The following is a description of a gene set: studied in species Homo sapiens Human Gene Set: BLANCO_MELO_COVID19_SARS_COV_2_LOW_MOI_INFECTION_A594_ACE2_EXPRESSING_CELLS_UP from publication Blanco-Melo D, Nilsson-Payant BE, Liu WC, Uhl S, Hoagland D, Møller R, Jordan TX, Oishi K, Panis M, Sachs D, Wang TT, Schwartz RE, Lim JK, Albrecht RA, tenOever BR (PMID 32416070) Genes up-regulated in SARS-CoV-2 low MOI infection (ACE2 expressing A549 cells, MOI: 0.2, 24hpi) Analysis of the transcriptional response to SARS-CoV-2 compared with other respiratory viruses, including MERS-CoV, SARS-CoV-1 (SARS), human parainfluenza virus 3 (HPIV3), respiratory syncytial virus (RSV), and IAV., and this is the list of marker genes: DCAF4L1, PTGS2, SNORA3B, SLCO5A1, FGG, ARHGAP40, SIX4 (NCBI Gene Id 51804), PER3, ZNF555, TCERG1L, MIR3685, NR4A1, SCARNA7, EREG, CCL4, LINS1, HRH3, CD300LB, INO80D, SNORD15B, ZNF654, DBP, IGFBP1, LSMEM1, ARHGAP30, CLK1, WRAP53, FST (follistatin), CCNL1, RIMOC1, FGA, GRHL1, FOXN2, TNF, NEURL3, H2AC15, IL1A, ZNF830, EGR1, SNORA28, ZBTB21, NFKBID, MIR3191, IER3, DDIT3, NGFR, SCARNA15, SNIP1, RASD1, VGF, BHLHE41, NFKBIA, NFKBIZ, BCL3, LBP (lipopolysaccharide binding protein), ARRDC3, IRF1, PPP1R15A, EFNA1, PTX3, ATF3, EGR3, SNORA63, GPR142, CD83, C1R, H2BC26, HNRNPU, ZNF596, FOS, LTB, FRS2, ZNF211, MIR23AHG, ICAM5 (NCBI Gene Id 7087), KLF10, CCL20, SAA2, CCL2 (C-C motif chemokine ligand 2), ZNF77, KMT2E-AS1, FOSB, ZBTB10, CXCL2, FOXD3, SNORA48, ZNF292, LINC00115, CEMIP, PRKXP1, PPM1E, CIART, HLA-B, ACHE, CLUHP3, CXCL1, MALAT1, BBC3, TNFAIP3, PPP4R4, JUNB, NBEAP1, SNORD50B, CSRNP1, C11orf96, MIR4453HG, H2BC18, SCARNA2, RLF, PRR14, ID1, EGR2, SELE, C2orf66 (NCBI Gene Id 401027), CSF3, H2BC20P, AURKAP1 (NCBI Gene Id 6791), CREBRF, ICAM1, FGB, NTNG2, RRS1-DT, CXCL8, ADM5, MAFF, ZNF57, ZNF764, ZNF121, H2BC21 (NCBI Gene Id 8349), PCF11, COL2A1, SOCS3, ZSCAN12P1, ZC3H12A, IL23A, IRF7, NR1D1, SERTAD2, IER2, NOTCH2NLA, NFKBIE, DUSP8, CEP85L, CXCL3, DYNLT2, PRG4, ARC, RNU6ATAC, FOXC2, EPM2AIP1, KDM6B, ZNF436, REL, ZBTB6, SNORA3A, ACAN, ZBTB43, NFYC-AS1 (NCBI Gene Id 100130557), SNORD97, NFIL3, ZFP36 (ZFP36 ring finger protein), ZNF184, ZNF267, IER5, PER1, FGF18, DLX2, LINC00472, PLEKHF2, NR4A3, CD200R1 (NCBI Gene Id 131450), SNORA25 (small nucleolar RNA, H/ACA box 25)